The following is a description of a gene set: from publication Chen Y, Wang X (PMID 31504780) studied in species Mus musculus Genes predicted to be targets of miRBase v22 microRNA mmu_miR_7214_3p in miRDB v6.0 with MirTarget v4 prediction scores > 80 (high confidence targets). Mouse Gene Set: MIR_7214_3P, and this is the list of marker genes: Xiap, Gtf3c2, Smg7, Zbtb18 (NCBI Gene Id 30928), Zfp462, Kmt2a, Castor2, Sccpdh, Ebna1bp2, Ccdc59, Tmed5, Ttc4 (NCBI Gene Id 72354), Btbd16, Galnt7, Rtn4, Uxt, Nol4, Kcnip1, Pnma2, Uqcc1 (ubiquinol-cytochrome c reductase complex assembly factor 1), Psip1, Luzp2, Slc25a3, Tti1, Dnali1, Tmed7, Stxbp1, Tmem132b, Stk17b, Dcun1d5, Fbxo42, Sar1a, Phf24, Hoxc4 (NCBI Gene Id 15423), Ppfia3, Galnt1, Rfesd, Zfp869, Crk, Tpt1, Zfp277, Tpx2, Pde1c, Hgh1, Flcn, Ccr3, Prpf4b, Colec12, Msl2, Tlr8, Pwwp2a, Rbpj, Glcci1, Cnot11, Tbx22, Tesk2, 2210016L21Rik, Wdr26, Fam169b, Ubp1, Gtpbp1 (NCBI Gene Id 97981), Myo6, Kifbp, Sh2d4a, Fstl3, Ror1, Bud23, Slc12a2, Cnot6, Mrpl57, Pou4f2, Etv6, Itga1, Car11, Esco1, Prokr2, Zfp970